The following is a description of a gene set: studied in species Mus musculus from publication Sansom OJ, Meniel VS, Muncan V, Phesse TJ, Wilkins JA, Reed KR, Vass JK, Athineos D, Clevers H, Clarke AR (PMID 17377531) Wnt target genes up-regulated after Cre-lox knockout of APC in the small intestine that require functional MYC. The APC gene encodes the adenomatous polyposis coli tumour suppressor protein, germline mutation of which characterizes familial adenomatous polyposis (FAP), an autosomal intestinal cancer syndrome. Inactivation of APC is also recognized as the key early event in the development of sporadic colorectal cancers, and its loss results in constitutive activity of the beta-catenin-Tcf4 transcription complex. The proto-oncogene c-MYC has been identified as a target of the Wnt pathway in colorectal cancer cells in vitro, in normal crypts in vivo and in intestinal epithelial cells acutely transformed on in vivo deletion of the APC gene; however, the significance of this is unclear. Therefore, to elucidate the role Myc has in the intestine after Apc loss, we have simultaneously deleted both Apc and Myc in the adult murine small intestine. Here we show that loss of Myc rescued the phenotypes of perturbed differentiation, migration, proliferation and apoptosis, which occur on deletion of Apc. Remarkably, this rescue occurred in the presence of high levels of nuclear beta-catenin. Array analysis revealed that Myc is required for the majority of Wnt target gene activation following Apc loss. These data establish Myc as the critical mediator of the early stages of neoplasia following Apc loss. Human Gene Set: SANSOM_WNT_PATHWAY_REQUIRE_MYC, and this is the list of marker genes: DVL3, MTAP, RABEP2, NLK, CCNE2, E2F1, PTCH1, SKP1, WIF1 (NCBI Gene Id 11197), CD44, AXIN2 (NCBI Gene Id 8313), ID3, EPHB3, PCBD1, SLC1A5, SOX4, SOX9, TNFRSF12A, TNFRSF19, ROCK1, ACTL6A, SLC1A3, MYC, TP53 (tumor protein p53), NKD1, LEF1 (NCBI Gene Id 51176), FXN, SP5, TCF7, SMC4, EDN1, MMP14 (NCBI Gene Id 4323), ASCL2, FOXA1, EPHB2, BMP7, GEMIN2, BAX, PARP1, IGFBP2, ID2, PLAT, DVL2, PTGS2, ROR2, FZD7, LECT2, SOX17, FRZB, LGR5, ARX, CUL1, CCN4, FZD6, CITED1, SEMA3C, TIAM1, APOD, LDB1, SIM2, MSX1, CSNK2A1, RUVBL1